The following is a description of a gene set: species: Homo sapiens from publication Chen Y, Wang X (PMID 31504780) Human Gene Set: MIR4447 Genes predicted to be targets of miRBase v22 microRNA hsa-miR-4447 in miRDB v6.0 with MirTarget v4 prediction scores > 80 (high confidence targets)., and this is the list of marker genes: C6orf141, CCDC97, SLC22A7, LIMD2, NFIC, AMOTL2, SEMA4G, RARA, EFNB1, BTBD9, CNNM1, GPR137, CDCA4, RIPOR1, SORBS1, MYO18A, TMEM132E, FIBCD1, KANK2, HOXB4 (homeobox B4), TTYH3, FBRS, ATG14 (NCBI Gene Id 22863), EMILIN3, KCNQ2, NFASC, BCORL1, GTDC1, STX1B, SNX30, ASB1, NSL1, PRRG1, SKI, RPAP3, NCAN, ZNF385A, NGFR, LAMC1, IGF2, TXK, PRELP, NOVA2, MTSS2, MFN2, MTHFSD (NCBI Gene Id 64779), MECP2, RNASE13, PHOSPHO1, GATAD2B, AVPR1A, MYO15A, PKM, CYP26B1, TSPAN9, LHX6, INHBC, METTL21A, STRIP1, DLGAP3, ICMT (isoprenylcysteine carboxyl methyltransferase), CBFA2T2, SLC6A17, IGFL3, PTPDC1, SCAMP5, PCYOX1L, HOXC4, ELMOD3, PTK7, KCNH2, TNKS1BP1, KMT5C, ARL5B, CPLX2, PLEKHM3, C20orf203, SPESP1-NOX5, SMARCD1, PDXK, DLX3, CAPN15, NECTIN1, KATNAL2, OPA3 (NCBI Gene Id 8186), DERL1, ZDHHC8, SH2B1, NOX5, CMIP, RSPO4, MTCL1, NACC2, URM1, MEF2D, MPL, MAP3K9, CCDC157, ADORA3, SLC7A8, ADD1, ZSWIM4, TXNRD1, MEX3A, AKAP13, PPP2R1A, RASAL2, BCL7A, PRLR, ABCD1, DNMT3B, ELMO2, PLEKHM1, SHISA6, H2AB1, KCNAB2, GJB4, CREB3L2, CFAP263, SCRT1, ZBTB4, CACNG2, DTX3, PDE4A, VWA5B2, TXNL4B, BCL2L1, CAPN6, ELAVL3, ZCCHC24, SYNGAP1, KCNK3, DDA1, NTSR1, POLM, C5AR1, ARPIN, TBX6, GCM1, LSAMP, DAGLA, DEF8, PAX5, NIPAL2, HCN2, VAMP2, HYDIN, ATP2A1, STAC2, IDH3B, PKN3, SUN2, SERTAD2, ASB6, ZFR2, ERN2, SPINT3, WSCD2, MMP24, HAAO (NCBI Gene Id 23498), GYS1, BARHL2, SEMA6A, CPNE5, MBD2, ZC3H7B, CDH4, ARRB1, G6PC2, MSN, RAB15, ANKRD13B, CNDP1, ZBED10P, ATP2A3, NXF1 (NCBI Gene Id 10482), BCL7B, SNPH, ARHGAP1, M6PR, COL5A3, GIT1, ACSF2, KIF21B, PYGO2, RNF5, TCF12, INTS6, IQGAP3, ZNF618, UGT3A1, TMEM63B, MLF2, SLC9A1, NFIX, IQSEC2 (NCBI Gene Id 4382), NUAK2, STUM, CENPI, CRLF2 (NCBI Gene Id 64109), SHISAL1, C14orf132, NXPH3, SPATA31D4, TUBB4A, SH3PXD2A, TRIM45, RGS6, DAB2IP, KSR2, DVL3, NKD2, TIE1, ATP13A1, SEPTIN6, RIMOC1, PLCH2, GARS1, P2RY4, EPHB2 (NCBI Gene Id 50980), SMTN (NCBI Gene Id 6525), KMT2B, CYP2W1, CASK, FOXP4, UBL5, SNAI1, CASTOR2, GALNT2, PDLIM3, TADA3, SMYD5, KALRN, TMEM164, SAMD4A, GMIP, TTC9, LZTS3, PRKACA, CCDC3, HIP1, TNNI1, PALM, KCNC1, PGGHG, USP20, RWDD2A, GDI1, TSHZ2, KLK5, ERF, UBTF, C1orf159, CMTR1, ARK2C (NCBI Gene Id 494470), SYT7, SLC4A2, ELAVL4, NACC1, ABCC6, MAG, ZDHHC15, ZNF512B, PSMF1, AGO1, MSI1, KMT2D, RAB36, TTC22, WWP2, CENPT, ELOVL1, ATG16L1, PLPPR5, C5orf15, SEMA4C, ADARB2, SCN4B, STMN3, LDB3, CARM1, PALD1, SUV39H1, PDPR, HOXC8, B4GALT5, DMRTB1, TRIM4, TMEM114